Given this list of marker genes POLD1, POLB, NEIL2, POLD3, UNG, PARP1, NEIL1, MPG, ADPRS, POLE3, POLE4, MBD4, POLE2, FEN1, PARG, PCNA, MUTYH, OGG1, RFC3, XRCC1, LIG1, NTHL1, RFC4, PARP2 (NCBI Gene Id 10038), LIG3, RPA2, RPA1, POLD2, RPA3, RFC5, POLE, RFC1, POLD4, PNKP, APEX1, RFC2, SMUG1, TDG, here is a description of the gene set: Human Gene Set: REACTOME_RESOLUTION_OF_ABASIC_SITES_AP_SITES species: Homo sapiens Resolution of Abasic Sites (AP sites)